Given this list of marker genes Ephb3, Fgf12, Mst1r, Fgf21, Flt3, Epha5, Fgf22 (fibroblast growth factor 22), Ltk, Smoc2, Fgfbp3, Flrt3, Sulf2, Creb3l1, Ntrk1, Insr, Musk, Pdgfrb, Fgf3, Flrt2, Ctnnb1, Epha10, Fgf8, Fgf15, Sulf1, Nrxn1, Prdm14, Gpc1, Fgf7, Epha6, Ext1, Ddr1, Fgf5, Iqgap1, Epha4, Crkl, Ngfr, Sos1, Fgf23, Fam20c, Fgfrl1, Fgfr4, Frs3, Ddr2, Fgf16, Fgfr2, Epha2, Csf1r, Fgf17 (fibroblast growth factor 17), Epha8, Rab14, Fgf10, Ntrk3, Ret, Dstyk, Hhip, Tie1, Fgf4, Pdgfb, Ephb2, Enpp1, Spry4, Fgf6, Ntrk2, Pdgfra, Itgb1, Kdr, Tyro3, Fgfbp1 (NCBI Gene Id 14181), Ndst1, Shisa2, Flt1, Erbb4, Mertk, Flrt1, Ror2, Fgf14 (fibroblast growth factor 14), Gata3, Tbx2, Fgfr3, Runx2, Prkd2 (protein kinase D2), Shcbp1, Frs2, Igf1r, Ros1, Ephb1, Zdhhc16, Cep57, Erbb2, Churc1, Met, Nptn, Fuz, Spry1, Fat4, Ccn2, Alk, Egfr, Spry2, Rhod (NCBI Gene Id 11854), Fgf20, Ift80, Kif16b, Nog, Trim71, Tek, Fgf9, Epha7, Epha1 (NCBI Gene Id 70581), Fgf2, Apln, Kit, Epha3, Ptpn11, Ofd1, Wnt4, Tcf7l2, Axl, Insrr, Ephb4, Fgf1, Fgfr1, Grb2, Kl, Wnt5a, Flt4, Fgf18, Klb, Chrd, Thbs1, Lrit3, here is a description of the gene set: Mouse Gene Set: GOBP_FIBROBLAST_GROWTH_FACTOR_RECEPTOR_SIGNALING_PATHWAY species: Mus musculus The series of molecular signals generated as a consequence of a fibroblast growth factor receptor binding to one of its physiological ligands.